Given this list of marker genes Chst9, Chsy3, Vcan, Chst12, Chst15, Dcn, Chst11, Bcan, Csgalnact2, Chst13, Chsy1, Bgn, Chst3, Csgalnact1, Cspg4, Chst7, Cspg5, Chpf2, Chpf, here is a description of the gene set: Chondroitin sulfate biosynthesis studied in species Mus musculus Mouse Gene Set: REACTOME_CHONDROITIN_SULFATE_BIOSYNTHESIS